The following is a description of a gene set: Human Gene Set: GOBP_MAST_CELL_CYTOKINE_PRODUCTION Any process that contributes to cytokine production by a mast cell. species: Homo sapiens, and this is the list of marker genes: SYK, BCL6, KIT, FCER1G, RABGEF1, NR4A3, BCL10